The following is a description of a gene set: Human Gene Set: GOBP_GLYCINE_METABOLIC_PROCESS studied in species Homo sapiens The chemical reactions and pathways involving glycine, aminoethanoic acid., and this is the list of marker genes: RIDA, SHMT2, PHGDH, GLDC, AGXT, NDP, AGXT2, GLYAT, AMT, HAO1 (hydroxyacid oxidase 1), SHMT1 (NCBI Gene Id 9316), GCSH, BAAT